Given this list of marker genes CFH, C4BPB, CD55, C1QB, SERPING1, C7, C3, CFB, C5, CFI, C1QA (NCBI Gene Id 712), C4A, CR2, C1R, C4B, CLU, C8A, CFHR1, C6, C9, C1S, C4BPA, C2, here is a description of the gene set: species: Homo sapiens Human Gene Set: MODULE_130 Complement.